The following is a description of a gene set: Genes up-regulated in peripheral blood mononuclear cell 7d after second dose vs 7d after first dose in adult (30-70) after exposure to Menveo/ACWYVax, time point 7D. Comment: second dose at 28 days from publication O'Connor D, Clutterbuck EA, Thompson AJ, Snape MD, Ramasamy MN, Kelly DF, Pollard AJ (PMID 28137280) Human Gene Set: OCONNOR_PBMC_MENVEO_ACWYVAX_AGE_30_70YO_7DY_AFTER_SECOND_DOSE_VS_7DY_AFTER_FIRST_DOSE_UP species: Homo sapiens BACKGROUND: Neisseria meningitidis is a globally important cause of meningitis and septicaemia. Twelve capsular groups of meningococci are known, and quadrivalent vaccines against four of these (A, C, W and Y) are available as plain-polysaccharide and protein-polysaccharide conjugate vaccines. Here we apply contemporary methods to describe B-cell responses to meningococcal polysaccharide and conjugate vaccines. METHODS: Twenty adults were randomly assigned to receive either a meningococcal plain-polysaccharide or conjugate vaccine; one month later all received the conjugate vaccine. Blood samples were taken pre-vaccination and 7, 21 and 28 days after vaccination; B-cell responses were assessed by ELISpot, serum bactericidal assay, flow cytometry and gene expression microarray. RESULTS: Seven days after an initial dose of either vaccine, a gene expression signature characteristic of plasmablasts was detectable. The frequency of newly generated plasma cells (CXCR3<sup>+</sup>HLA-DR<sup>+</sup>) and the expression of transcripts derived from IGKC and IGHG2 correlated with immunogenicity. Notably, using an independent dataset, the expression of glucosamine (N-acetyl)-6-sulfatase was found to reproducibly correlate with the magnitude of immune response. Transcriptomic and flow cytometric data revealed depletion of switched memory B cells following plain-polysaccharide vaccine. CONCLUSIONS: These data describe distinct gene signatures associated with the production of high-avidity antibody and a plain-polysaccharide-specific signature, possibly linked to polysaccharide-induced hyporesponsiveness., and this is the list of marker genes: AHCYL1, MED15, TNPO3, SPTBN1, SUPT5H, HSP90AB1, AKAP8L, TBC1D17, RALGPS2, C7orf50, PROK1, BRMS1, VPS13C (NCBI Gene Id 57581), MYL6, ZNF512B, TM9SF2, SIVA1, PSMC3, YAF2, RTN4, SASH3, SAMD4B, ERGIC3, MED24, UBE2Z, POLR1B, TAFAZZIN, PPM1B, USP21, TIMM17B, PA2G4, POLR3A, RPL13, SND1, CCDC12, TTC17, DYNC1H1, ACIN1, STIP1, MYO1G, TMEM219, CCDC167, MARCHF6, CYP4F12, ACAP1, SLC38A7, DAXX, ANKRD13D, FKBP2, CD3E, CUX1, KPNA6, BRD3, KAT6B, TRIR, MICOS13, PPP2R1A, DIAPH1, OGDH, CBX5, SIN3B (NCBI Gene Id 23309), PHKA2, LPCAT4, NAA38, HYMAI, GMEB1, LITATS1, AIF1, TRIM4, LETM1, MAP4, FLNA, WHAMM, ZNF768, TMEM250, TMEM256, PCNX3, NRBP1, TRAPPC10, LONP2, PET100, SPOP, UGGT1, BATF, KDM2A (NCBI Gene Id 22992, lysine demethylase 2A), CHD4, CSNK2A3, CEBPE, ATP2B4, LNPK, MZT2A, SUPT6H, HOMER3, HPS5, TFF3, ROMO1 (reactive oxygen species modulator 1), PKN1, MRPL41, UBE2D2, CPNE5, ERC1, PPP1R10, NUDT22, STUB1, MRPS16, LSM7, ATP5MF, FOXP1, NOSIP, USF2, SYNJ2BP, TYMP, PLEC, KANSL1, HUWE1, CORO7, PCNX2, CPSF2, CARS1, EIF3B (eukaryotic translation initiation factor 3 subunit B), ZC3H11C, RPRD2, GTF2F1, SNTB2, RRP7A, CROCC, DIS3L2, TUBGCP2, HNMT, CLASRP, COL6A2, HDAC7, UBL5, APOBEC3C, APOBEC3D, APOL1, ILRUN, NFKB2, ARL6IP4, SURF2, ITGA2B, WASF2, RDM1, HAPLN3, TCEAL9, HMGA1